The following is a description of a gene set: studied in species Mus musculus Mouse Gene Set: GOMF_CARBOXYLESTERASE_ACTIVITY Catalysis of the reaction: a carboxylic ester + H2O = a carboxylate + an alcohol + H+., and this is the list of marker genes: Ces2h, Ces2e, Ces1c, Ces2c, Tnfaip6, Ces2a, Ces5a, Ces2b, Ces1d, Ces1a, Ces1f, Ces1e, Ces2g, Ces3a, Aldh2, Ces3b, Ces2f, Ces1h, Ces1b, Ces1g